Given this list of marker genes UNC13A, LPO, SYT12, LINC00927, OSTM1-AS1, BPIFA1, PKDCC, TTPA, STATH, SEMA5A, LINC01356, GALT, CLDN16, OR2F2, SLC22A25, LGI1, KARS1, AKAP8L, FAM9A, LINC02483, C2orf80, PDCD1LG2, ADAM3A, ADAM7, CAPN8, EFNA2, GP2, PKHD1, LY6E, ENSG00000253557, MARVELD3, CRB2, HOXB5, CCL13, FAM21EP, WDR88, GSTA3, SCTR, PCGEM1, EHD2, RAB40A, GRIK1, MIR30C2, SLC25A10, C14orf180, TOR1AIP2, FGF19, PTPN3, NTRK2, ZNF576, GUCY2F, TRPM3, CYP3A43, FCAMR, SLC45A2, VHL, CBX2, MOBP, LPAL2, TEX19, SH2B3, RBFOX2, LINC01095, FFAR1, C1QC, FGF4, ARR3 (arrestin 3), PRKAG2-AS2, PALMD, RTP3, ELOVL2, EDNRB, HRG, RAB40AL, HCN4, ZNF70 (NCBI Gene Id 7621), LRRC4C (leucine rich repeat containing 4C), PRR22, SORBS2, FAM110D, CLPS, FGF22, LINC00705, NPY2R, IL15RA, CHRD, EPIC1, TAS2R38, BRINP2, XDH, GDF5, CHP2, RRM2B, WDFY3-AS2, PANX3, ACKR2, CBLC, HS6ST2, CRYBB2, AIF1L, CECR2, RBP3, CHRND, DDX28, C4orf46, C1orf127, IHH, RASIP1, DDR1-DT, LRATD1, CYP4B1, LRRN4, PDHA2, FRK, PSCA, TAS2R41, SNHG4, TNFSF8, MED9, MYLK2, GPT, FSD2, ENSG00000245651, CELP, TRIM16L, RXFP1, TBX6, PFN4, SSTR2, C1orf167, CCER1, PRLR, SAMD1, UGT2B4, ALDH3A1, BLOC1S1, SAYSD1, CA5A, C1QB, PTGES, RGSL1, SNORA17B, CDON, EPHA7, GYPB, OR51B6, LINC01341, KCNJ6, IL17F, TCP11, PAX2, KRTAP5-8, KLHL35, HHIPL1, FBP1, SSH3, C1orf54, AGRP, PDLIM3, SHISA6, HBBP1, MTMR9LP, GDF9, CHRM5, FAR2P1, ENSG00000237250, CDH16, LOX, ENSG00000248540, INE1, MBOAT2, S100A5, ICA1 (NCBI Gene Id 3382), HGFAC (HGF activator), NUDT19, DRAIC, C6orf62, PCDHB15, PDE1C, XPNPEP2, CCDC87, ANO4, SMTNL2, PCDHB18P, RBMY2FP, GRIA4, SLC17A6, NEUROD1, here is a description of the gene set: Human Gene Set: GSE29614_DAY3_VS_DAY7_TIV_FLU_VACCINE_PBMC_UP Genes up-regulated in comparison of peripheral blood mononuclear cells (PBMC) from TIV influenza vaccinee at day 3 post-vaccination versus those at day 7 post-vaccination. Systems vaccinology has emerged as an interdisciplinary field that combines systems wide measurements and network and predictive modeling applied to vaccinology. Here we used the systems vaccinology approach to study the molecular mechanisms underlying the innate responses to the trivalent inactivated influenza (TIV) and live attenuated influenza (LAIV) vaccination in humans, and to identify early gene signatures that predict the magnitude of the antibody responses to influenza vaccination. studied in species Homo sapiens from publication Nakaya HI, Wrammert J, Lee EK, Racioppi L, Marie-Kunze S, Haining WN, Means AR, Kasturi SP, Khan N, Li GM, McCausland M, Kanchan V, Kokko KE, Li S, Elbein R, Mehta AK, Aderem A, Subbarao K, Ahmed R, Pulendran B (PMID 21743478)